The following is a description of a gene set: The directed movement of a vesicle along a microtubule, mediated by motor proteins. This process begins with the attachment of a vesicle to a microtubule, and ends when the vesicle reaches its final destination. species: Mus musculus Mouse Gene Set: GOBP_VESICLE_TRANSPORT_ALONG_MICROTUBULE, and this is the list of marker genes: Bloc1s4, Bloc1s5, Ap3s2, Kif5a, Madd, Bicdl1, Ap3s1, Stk11, Bicdl2, Bloc1s1, Map2k1, Kif1c, Trak1, Ap3b2, Cnih2, Kif5b, Htt, Map2, Ap3m1, Kif1a, Hap1, Rab1a, Rasgrp1, Ndel1, Dtnbp1, Bloc1s2, Bloc1s3, Prkcz, Dync1i1, Borcs5, Cln3 (NCBI Gene Id 12752), Fyco1, Trim46, Spg11, Sybu, Mecp2, Fbxw11, Nde1, Snapin, Kifc1, Kif1b, Kif28, Ap3b1, Ap3d1, Bloc1s6, Ap3m2, Pafah1b1, Kif13a, Kif16b, Trak2